The following is a description of a gene set: from publication Brocke-Heidrich K, Kretzschmar AK, Pfeifer G, Henze C, Löffler D, Koczan D, Thiesen HJ, Burger R, Gramatzki M, Horn F (PMID 12969979) Genes changed in INA-6 cells (multiple myeloma, MM) by re-addition of IL6 after its initial withdrawal for 12h. Interleukin 6 (IL-6) is a growth and survival factor for multiple myeloma cells. As we report here, the IL-6-dependent human myeloma cell line INA-6 responds with a remarkably rapid and complete apoptosis to cytokine withdrawal. Among the antiapoptotic members of the B-cell lymphoma-2 (Bcl-2) family of apoptosis regulators, only myeloid cell factor-1 (Mcl-1) was slightly induced by IL-6. Overexpression studies demonstrated, however, that IL-6 does not exert its survival effect primarily through this pathway. The IL-6 signal transduction pathways required for survival and the target genes controlled by them were analyzed by using mutated receptor chimeras. The activation of signal transducer and activator of transcription 3 (Stat3) turned out to be obligatory for the survival of INA-6 cells. The same held true for survival and growth of XG-1 myeloma cells. Gene expression profiling of INA-6 cells by using oligonucleotide microarrays revealed many novel IL-6 target genes, among them several genes coding for transcriptional regulators involved in B-lymphocyte differentiation as well as for growth factors and receptors potentially implicated in autocrine or paracrine growth control. Regulation of most IL-6 target genes required the activation of Stat3, underscoring its central role for IL-6 signal transduction. Taken together, our data provide evidence for the existence of an as yet unknown Stat3-dependent survival pathway in myeloma cells. species: Homo sapiens Human Gene Set: BROCKE_APOPTOSIS_REVERSED_BY_IL6, and this is the list of marker genes: EIF5, IRF4, EIF4E, CDK17, BCL3, MYO18A, PTPN11, CCNC, EVI2B, SF1, RAPGEF4, PNO1, TPM4, RHOBTB3, CD44, FOXO3, MARCKS, ZFP36L2, PTP4A1, MAP1B, GADD45A, HSPA13, FAM30A, IER2, SOCS3, OAS1, DYRK3, PTPRG, IRF9, TWF1, DAPK1, ZBTB11, DOHH, NMI, JUN, HEG1, LPCAT4, TMEM184B, DNAJB9, TXNDC9, NAMPT, BHLHE40, POU2F2, AP1S2, SOX2, GATM (NCBI Gene Id 65211), IFNGR1 (interferon gamma receptor 1), STAT3, SIK1, PAN2, DUSP5, JUNB, GAS6, RCN2, GRB2, ID3, GADD45B, IRF1, EEF1E1, TMED7, CD180, ST3GAL6, SPP1, RALA, TMF1, ANAPC10, TNFSF10, LDLR, ATP2B4, PHTF2, NCBP2, IL6ST (interleukin 6 cytokine family signal transducer), STAT1, BCL2L11, RB1, POU2AF1, SREK1IP1, ZFP36, ACP3, SGK1, RGS16 (NCBI Gene Id 6004), MAZ, EVI2A, GNA13, SBNO2, FAM3C, PLSCR1, SRPK2, MT1H, SLC16A6, ADIPOR2, BORCS8-MEF2B, LITAF, BCL6, CAV2, HCK, PDGFRA, ELL2, CADPS, WIPI1, RAD1, VWA5A, LTBP1, PTP4A3, EPB41L2, SOCS1, MAP3K8, SLA, MT1X (metallothionein 1X), MSMO1, MCL1, IRAG2, PRDM1, MAFF, PIM2, PIM1, DNAJA2, ARFGAP3, MYLK, CXCR4, TGIF1, DUSP3, SH2D2A, ID2, CHST15, PLEKHB2, POLR3F, MUC1, ZNF101, CEBPB, HNRNPU, ID1, DEPP1, SLC2A3, RNF13, STK17B, MX1, CD8B, HSPA1A, MAPKAPK2, HBEGF, CCL2, ICAM1, FLOT1, AMPD1, DPM1